Given this list of marker genes Chac1, Uroc1, Anpep, Ftcd, Pdhb, Nudt19, Mep1a, Abcc2, Sgms2, Slc5a6, Cps1, St6galnac6, Plpp2, Furin, Pdzd11, Cers6, Gsdmd, Nit1, Mecr, Oxsm, Rock2, Elovl3, Pcsk6, Aldob, Bace1, Spon1, Aass, Ethe1, Arl6ip5, Cryaa (crystallin, alpha A), P4hb, Acacb, Slc27a3, Gda, B4galt5, Pgk1, Smpdl3a, Nsmaf, Acot3, Ormdl1, Degs1, Acot4, Degs1l, Pdhx (pyruvate dehydrogenase complex, component X), Unc13a, Nagk, Pin1rt1, Tmed10, Oxct2a, Casp3, Pnpla1, Pdk2, Hmgcs1, Tm9sf2, Prnp, Pemt, Dpep1, Gsta3, Pcsk1, Plpp3, Vnn3, Pm20d1, Sptlc2, Scg5, Ifng, Cryab, Hexb, Gstp3, Elovl7, Prcp, Abcd1, Cmah, Otc (ornithine transcarbamylase), Lct, Dld, Pdk3 (pyruvate dehydrogenase kinase, isoenzyme 3), Neu4, Mvk, Gstt2, Rela, Pdk4, Casp1, Mgst1, Cyp4f39, P2rx1, Pcsk5, Gpam, Gstm2, B4galnt1, B4galt3, Aldh1l2, Ctsl, Tlcd3b, Pmvk (phosphomevalonate kinase), Mmachc, Sptssb, Cert1, Abca8b, Nt5c1a, Smpd5, Nmnat2, St8sia3, Pcsk4, Aldh1l1, Pin1, Acss2, Enpp7, Vapa, Plpp1, Dlst, Nudt8, P2rx7, Uox, Gstm6, Pipox, Gsta13, Yipf5, Vdac1, Gstt4, Gnpda2, Enpep, Dlat, Psap, Hsd11b1, Disp1, Bloc1s6, Slc25a16, Oplah, Paqr4, Pdha1, Amdhd2, G6pd2, Sptlc3, Abca2, Acot8, Nat8f7, Carnmt1, Mpc1, B3galt4, Gstp2 (glutathione S-transferase, pi 2), Gsto2, Them5, Acsm1, Osbp, Nans, Clu, Dyrk1a, Ogdh, Sucla2, Hap1, Slc30a8, Carns1, Gsta5, Gm2a, Klk1b1, Plaat5, Abhd4, Dhfr, Kynu, Mtrr, Gclm, Rtn2, Rtn4, Pcsk1n, Nat8, 6430550D23Rik, Csl, Sphk1, Mmaa, Far2, Mlycd, Tnf, Acot5, Idh1, Fa2h, St6galnac1, Gsk3a, Gba1, Pank3, Vnn1, Mgat3 (NCBI Gene Id 68766), Ggt7, Slc35a1, Acnat2, Acot2, Ggt5, Psenen, Itgb8, Mthfsl, Neu1, Smpd4, Acsl5, Arg1, Pcsk2, Nmnat3, Crot, Abca7 (ATP-binding cassette, sub-family A member 7), Mmut, Acsl6, B4galt4, Cs (citrate synthase), Ifngr1, Nags, Tigar, Arg2, Far1, Mgst2, Nfe2l1, Aanat (NCBI Gene Id 11298), Slc1a2, Nat8b-ps, Ormdl2, Gsr, Acaa2, Chst8, Acsm5, Gstt3, Ace2, Acot1, Cpn1, Txnrd3, Abca12, Htra2, Ugcg, Nampt, Asl, Casp7, Ace, Coasy, Acer1, Gstm4, Xpnpep1, Sod1, Alpi (alkaline phosphatase, intestinal), Gla (galactosidase, alpha), Cln6, Cmas, Trp53, Lrrtm3, Eed, Rack1, Aaas, Agk, Baat, Neu2, Cln8, Rps23rg1, Gsta2, Btd, Slc25a42, Hmgcr, Urad, Suclg1, Acsl1, Gnpda1, Ppcs, Ugt8a, Acsm3, Bin1, Acadsb, Aph1a, Acot9 (acyl-CoA thioesterase 9), Cebpa, Degs2, Gstz1, Gsto1, Prkcd, Hmgn5, Ncstn, Slc7a11, Atf4, Renbp, Galc, St6galnac4, Rtn1, Cers1, Dnph1, Bckdk, Nox1, Acer3, Hmgcl (NCBI Gene Id 230831), Gpat4, St6gal1, Slc30a5, Pdk1, Ece2, Naaa, Acot6, Hnf4a, Pank1, Gstm7, Aph1c, Becn1, Nnmt, Alox12b, Gba2, Cth (NCBI Gene Id 99582), St6galnac3, Hal, Amdhd1, Nt5c1b, Chac2, Mcee, Bace2, Elovl5, Smpd3, Acat1, Dcakd, Acer2, Acaca, Corin, St8sia6, St3gal3, Glo1, Asah1, Fut7, Ccn1, Cel, Ntrk2, Shmt1 (NCBI Gene Id 97731), Napepld, Pam, Psen2, Agmat, Sgpl1, Smpdl3b, Sod2, Lrp1, Acot7, Acot10, Igf1, Cers2, Fasn, Hexa, Elovl6, Elovl4, Asmt, Slc1a1, Mccc2, Pdha2 (NCBI Gene Id 229888), St3gal1, Gss, G6pdx, Ide, Rtn3, Cers5, Plaat3, Aph1b (aph1 homolog B, gamma secretase subunit), Psen1, Tmed10-ps, Mlst8, Gne, St3gal2, B3galt1, St6galnac5, Csnk1e, Gstt1, Hmgcs2, Sphk2, Nr1h4, Naglu, Ggt1, Gstm5, Gcdh, Ins2 (NCBI Gene Id 16334), Cers3, Nudt7, Mme, Folr1, Pla2g4e, Ece1, Acsm2, Eif2ak3, Gal3st1, Acsl4, Nmnat1, Mtor, Hlcs, Trem2, Acot11 (acyl-CoA thioesterase 11), Rock1, St8sia4, Nanp, Sp1, Ppcdc, Gstp-ps, Efna1 (ephrin A1), Sorl1, Acly, Gga3, Allc, Gstp1, Gzmb, Cers4, Nt5c2 (5'-nucleotidase, cytosolic II), St6gal2, Gsta4, Npl, Chrna7, B3galt2, Neu3, Sirt3, St8sia2, Gm6993, Enpp1, Sptlc1, Hpgds, Mvd, Elovl1, Pank2, Aadat, Dgat1, Plaat1, Pla2g15, Pank4, B4galt6, Htt, Sptssa, Samd8, Gsap, Abcg1, Ldlr, Pnp, Acnat1, Adam10, Acsl3, Tpk1, Ren1, Glb1, Cpe, Ass1, Smpd2, Rptor, Acss1, Hsd17b4, Ada, Mpc2, Smpd1, Ero1b, Pla2g6, Acsm4, Abcc1, Tnfrsf1a, Slc2a13, Nat8f1, Cpa3, Acot12, Asns, Ctsh, Dgat2, Zfp750 (zinc finger protein 750), Suclg2, Apoe, Hagh, Gstk1, Tdo2, Prep, Gpx1, Ehhadh, Ggt6, Ndp, Fh1, Aloxe3, Ormdl3, Fitm2, Snca, Picalm, Gstm3, Glyat, Dpep2, Pm20d2, Hid1, Ctns, Epha4, Atp6ap2, Lrp4, Gclc, Eef1ece2, Asah2, Nfe2l2, Hsp90b1, Prf1, Slc16a12 (solute carrier family 16 (monocarboxylic acid transporters), member 12), Urah, Cd36, Gsta1, Nt5c, Ces1d (carboxylesterase 1D, NCBI Gene Id 104158), Sgms1, Cerk, Xdh, Dip2a, Apeh, Gstm1, Abca8a, here is a description of the gene set: Mouse Gene Set: GOBP_AMIDE_METABOLIC_PROCESS The chemical reactions and pathways involving an amide, any derivative of an oxoacid in which an acidic hydroxy group has been replaced by an amino or substituted amino group, as carried out by individual cells. species: Mus musculus